Given this list of marker genes Cd300a, Slc18a2, Fcer1g, Syk, P2rx1, here is a description of the gene set: Mouse Gene Set: GOBP_SEROTONIN_PRODUCTION_INVOLVED_IN_INFLAMMATORY_RESPONSE The synthesis or release of serotonin following a stimulus as part of an inflammatory response, resulting in an increase in its intracellular or extracellular levels. studied in species Mus musculus